Given this list of marker genes ECE1, EPS15, PTPN1, PTPN2, MTMR2, CHMP5, PHETA2, VAMP3, PLEKHA3, PEX1, SCRIB, BVES, ITCH, PIK3R4, EHD3, FURIN, PEX10, RNF43, TRAT1, ARAP1, CAPN1, ANXA2, PHETA1, MYLIP, APOE, AP1AR, CTSD, SH3GLB1, GIT1, PEX2, MVB12A, UVRAG, ABCA2, TBC1D16, PSEN1, ZNRF3 (zinc and ring finger 3), BECN1, LMTK2, SMURF1, NEDD4 (NCBI Gene Id 4734), PLEKHJ1 (NCBI Gene Id 55111), LGMN, GRIA1, LAPTM5, CAMLG, FUT8, PEX12, PEX6, NSG1 (neuronal vesicle trafficking associated 1), REP15, RAMP3, PCSK9, LAMTOR1, GPRASP1 (G protein-coupled receptor associated sorting protein 1), NEDD4L, DTX3L, CDK5, LDLR, ACHE, PEX5, USP9X, INPP5F, ARFGEF2, SNCA, TGFB1, HAMP, SNX25, NSF, ALS2, BECN2, KIF16B, SNX16, RAB29, RAB11B, OPTN, SORL1, here is a description of the gene set: Human Gene Set: GOBP_RECEPTOR_METABOLIC_PROCESS species: Homo sapiens The chemical reactions and pathways involving a receptor molecule, a macromolecule that undergoes combination with a hormone, neurotransmitter, drug or intracellular messenger to initiate a change in cell function.